The following is a description of a gene set: part of: Sulfur amino acid metabolism species: Homo sapiens Transsulfuration is the interconversion of homocysteine and cysteine, and it fully takes place in bacteria and some plants and fungi. Animals however have only one direction of this bidirectional path, the synthesis of cysteine from homocysteine via cystathionine. Because excess cysteine is degraded to hydrogen sulfide, which is now known as a neuromodulator and smooth muscle relaxant, this pathway is also the main source of its production, which takes place in the cytosol, as well as in extracellular space (Dominy & Stipanuk 2004, Bearden et al. 2010). Reactome Pathway: Cysteine formation from homocysteine, and this is the list of marker genes: CTH, CBS